Given this list of marker genes Washc4, Dnajc13, Washc3 (NCBI Gene Id 70627), Capza1b, Washc5, Wipf3, Snx27, Capza1, Rcsd1, Washc2, Capzb, Washc1, Tbc1d23, here is a description of the gene set: Mouse Gene Set: GOCC_WASH_COMPLEX species: Mus musculus A protein complex that localizes at the surface of endosomes, where it recruits and activates the Arp2/3 complex to induce actin polymerization. In human, the WASH complex is composed of F-actin-capping protein subunits alpha and beta, WASH1, FAM21, KIAA1033, KIAA0196 and CCDC53.